Given this list of marker genes Maged1, Amotl1, Golga7b, B3gnt9, Ccdc198, Bard1, Mpp7, Slfn8, Psmd9, Ddias, Arhgef37, Adamts15, Topbp1, Sash3, Plin5 (NCBI Gene Id 66968), Zfc3h1, Cdk5r2, Prkab2, Klf14, Ildr2 (NCBI Gene Id 98467), Tub, Gfap, Cd38, Pecam1, Nicn1, Eef2k, Ssh2, Rdh5, Slfn9, Tmc7, Usp7 (NCBI Gene Id 98021), Rab26, Cenpu, Tmem150b, Hapln4, Amer3, Trub2, Rab40b, Fbxw7, Asxl3, Sec14l1, Ky, Scarb1, Ccdc43, Mief1, Tnrc6b, Vwa1, Ptpa, Aak1, Lipk, Usp4, Il23r, Dexi, Spesp1, Gk, Sars2, Dpm2, Dhdds, Rpf2, H13, Tcf25, Synpo2l, Stac2, here is a description of the gene set: from publication Chen Y, Wang X (PMID 31504780) Mouse Gene Set: MIR_6971_3P Genes predicted to be targets of miRBase v22 microRNA mmu_miR_6971_3p in miRDB v6.0 with MirTarget v4 prediction scores > 80 (high confidence targets). species: Mus musculus